The following is a description of a gene set: Human Gene Set: GOBP_REGULATION_OF_EPITHELIAL_CELL_DIFFERENTIATION studied in species Homo sapiens Any process that modulates the frequency, rate or extent of epithelial cell differentiation., and this is the list of marker genes: AQP3, WNT10B, IPO7, GDF3, S1PR2, ETV4, PTCH1, ZDHHC21, STAT5B, LIF, MSX2, GATA3, MIR150, SERPINE1, CDH5, F11R, XDH, IFNG, GDNF, ATOH8, CLDN5, MIR21, IL1B, WNT9B, HES5, MAFG, VDR, ABCA12, SOX9, CEACAM1, MYCL, RFX3, MYCN, FOXJ1, NCOA3, FGF10, PRKCH, FST, ZFP36, TNF, TRIM16, CCND1, TLR9, SFN, MIR18B, EZH2, FOXE3, NFE2L1, LHX1, MIR1-1, ALOX15B (NCBI Gene Id 247), ETV2, BMP6, SPRY2, TNFRSF1A, PROC, KRT84, APOLD1, S1PR3, SMO, WWTR1, EXTL3, TMEM100 (transmembrane protein 100), SFRP4, HES1, IL20, NOTCH4, PLAAT4, ADD1 (NCBI Gene Id 118), CEBPB, ZBED2, FGF2, TP73, BMP2, MIR34A, MIR204, SGPP1, IL13, ERRFI1, REG3A, MAFF, PTCH2, TP63, HOXA7, ROCK1, CDKN1C, JAG1, NKX2-2, NKX6-3, BMP7, PPP1R12A, STAT5A, VEZF1, SPRED1, SPRR5, PAX2, AHI1, ZFP36L1, MIR125B1, NUMA1, FOXC1, FOXJ2, IKBKB, DSG2, KDF1, PKP1, CD24, ZEB2, KRT36, BLTP1, BAD, CDKN1B, KRAS, MACROH2A1, BTG1, PRLR, MIR29B1, MED1, KEAP1, MIR99B, RPTOR, KLF7, GRHL1, LEF1, CTNNB1, MIR181B1, SIX2, SRSF6, MIR199B, NME2, DSPP, HEY2, MESP1, VEGFA, ATOH1, PRKX, SULT2B1, MIR518B, MMP9, MIR10A, GDF2, CAV1, MIR302A, NODAL, TBX3, NOTCH1, FRZB, FOXN1, ROCK2, PAX6 (paired box 6), VCL, MIR200C, SPRED3, STAT1, ACVRL1, SPRED2, MIR181A2, PAX8, MIR495, PROM1 (prominin 1), AJAP1, SPRY1, CD109, REG3G, CYP27B1, OSR1, YAP1, DLL1, ESRP1, ZEB1, PLCB1, MACROH2A2, NKX6-1, OVOL2, MSX1, ASCL1, BMP4